Given this list of marker genes DSE, KAT6B, FGFRL1, CHST14, CPLX1, CTBP1, NSD2, LETM1 (NCBI Gene Id 3954), WNT4, here is a description of the gene set: Human Gene Set: HP_MALROTATION_OF_SMALL_BOWEL Malrotation of small bowel A deviation from the normal rotation of the midgut during embryologic development with mislocalization of the small bowel. studied in species Homo sapiens